The following is a description of a gene set: studied in species Homo sapiens from publication Rorie CJ, Thomas VD, Chen P, Pierce HH, O'Bryan JP, Weissman BE (PMID 14973077) Neuroblastoma (NB) and the Ewing sarcoma (ES)/peripheral primitive neuroectodermal tumor (PNET) family are pediatric cancers derived from neural crest cells. Although NBs display features of the sympathetic nervous system, ES/PNETs express markers consistent with parasympathetic differentiation. To examine the control of these differentiation markers, we generated NB x ES/PNET somatic cell hybrids. NB-specific markers were suppressed in the hybrids, whereas ES/PNET-specific markers were unaffected. These results suggested that the Ews/Fli-1 fusion gene, resulting from a translocation unique to ES/PNETs, might account for the loss of NB-specific markers. To test this hypothesis, we generated two different NB cell lines that stably expressed the Ews/Fli-1 gene. We observed that heterologous expression of the Ews/Fli-1 protein led to the suppression of NB-specific markers and de novo expression of ES/PNET markers. To determine the extent of changes in differentiation, we used the Affymetrix GeneChip Array system to observe global transcriptional changes of genes. This analysis revealed that the gene expression pattern of the Ews/Fli-1-expressing NB cells resembled that observed in pooled ES/PNET cell lines and differed significantly from the NB parental cells. Therefore, we propose that Ews/Fli-1 contributes to the etiology of ES/PNET by subverting the differentiation program of its neural crest precursor cell to a less differentiated and more proliferative state. Neuroblastoma markers down-regulated in neuroblastoma cell lines expressing ESWR1-FLI1 fusion protein. Human Gene Set: RORIE_TARGETS_OF_EWSR1_FLI1_FUSION_DN, and this is the list of marker genes: GATA2, CRMP1, APC2, SFRP1, SCG2, NREP, DBH, PRPH, TMOD1, GATA3, RIMBP2, DLK1, ELAVL3, MYCN, ENPP2, MLLT11, KIF5C, GAP43, DCX, DDC (NCBI Gene Id 9492), ISL1, TRIB2, CD24, ARHGAP4, CHGB, RGS5, INA, FEV